The following is a description of a gene set: studied in species Homo sapiens Human Gene Set: VDR_Q6 Genes having at least one occurrence of the motif CNSNNTGAACCN in the regions spanning 4 kb centered on their transcription starting sites. This matches the VDR transcription factor binding site V$VDR_Q6 (v7.4 TRANSFAC)., and this is the list of marker genes: CFAP100, NDUFS2, SEMA4A, TMPO (thymopoietin), CDKN2B, WFIKKN1, FKBP14, FGF10, ZNF593, DNMT3A, RNF11, ASS1, VAX1, DNAJC11, CDK18, TMIGD1, TSSK3, SCML1, PPP2R2B, PDRG1, KIF1C, SPACA6, MTF2, MAPK6, ASXL1, PITPNM2, ZFHX3, NEO1, CCDC120, TMEM132E-DT, NGF, PIF1, C10orf71, LRRFIP1, NIPBL, CEBPB, VEZF1, KAT5, SOX5, GRK1, NTNG2, NECTIN1, DQX1, ZNF205 (NCBI Gene Id 7759), OTUD7B, TRIT1, TNR, BFSP2, SLC36A2, MAP4K2, CLOCK, ADCY2, PGGHG, LPCAT3 (NCBI Gene Id 10162), FOSL1, CYP26A1, PABIR3, KDM3A, CA11 (carbonic anhydrase 11, NCBI Gene Id 770), AGPAT3, OLFML2A, FBXO36, STRA6, ZNRF1, FBXL19, CDK15, ZC3H11A, TSSK4, RBPJ, RND3, ROCK1, ZNF710, FAM170A, LINC00314, IKZF2, GRIN2A, EBF2, CLTA, SLC7A7, CALCR (NCBI Gene Id 799), APOO, ARHGAP22, CCNL1, ROCK2, FOXA1, DMRT2, TUSC3, SSH2, EIF4E, SLC25A10, ZNF133, EFNA4, KLK8, KIF13A, HOXB6, TMEM150A, HOXA5, POLR3D, COX4I2, GPR158, PPP4R1, SRSF6, ADGRB1, PABPC1, ZNF688, BCAM, EMID1, LHX2, CHMP4B, PLEKHA8, CD3E, ATP2B3, HOXD3, ASB7, SNCB, ELF4, C6, VCAN, ABCD2, RPL3, FLYWCH2, GREM1, NR1D1, PYY, HNRNPR, ZSCAN20, MST1, HOXC4, PABPC3, NTRK2, ZNF532, TRIM29, MYT1, RABL6, SIPA1, CLUH, KLF15, ENPP7, SP7, HPCA, HHEX, FBXL20, HAUS3, MRTFA, PCF11, ID4, FBXL19-AS1, XPO1, LINS1, RARB, SLC39A11, FGF9, ARHGEF15, SPATA20, NRDC, ASAP1, KIF1B, GNB2, KLF4, ACO2, PIK3R1, S100G, ITM2B, ZNF800, MNT, GRIA3, PMP22, COL11A2, SAT1, MSI1, RNF123, RASIP1, DNAJC14, CD2BP2, CHMP2B, TRIM33, DMAC2, HOXB2, GRM3, BEX3, SIX4, GLI1, IRX4, KPNB1, CCNI, TSC22D3, ZC3H14, PKN1, PKP3, SEMA3B, ARL6IP1, ZPLD1, LAMP2, KCNJ13, STX6, RCOR2, GPBP1, AGO1, DDX17, ADGRL1, NCDN, TMEM185A, CD40LG, BARHL2, INCA1, SYNCRIP, ATP1B4, TMEM39A, BOC, CTLA4, ACOT8, TENM3-AS1, RAPGEF4, DLG2, GNL3LP1, PITX2, TMEM132E, CRHR1, ZNF503, RUNX1T1, TCF12, GSC, COL19A1, PHF21A, TFAP2C, EDN3, MACO1, TTBK2, SYT9, USF1, GBA2, OVOL1, ZSWIM3, KDM2A, SSBP3, TLNRD1, PAX6, CDX1, TSPAN13, SLC25A5, USP49, A1CF, ESRRG, PDGFC, RND2, CELF1, POLD1, RBBP6, SLC4A4, FAAP100, CD248, POU4F3, PODNL1, FXYD3, CLIC5, NLGN2, ARHGEF7, FOXD3, CXorf58, SYT14, SLC43A2, PCGF2, FGF14, GREB1, DDIT3, ADAMTS4, PCSK1N, CDK16 (cyclin dependent kinase 16), WNT5A (Wnt family member 5A), FGF17, CYP24A1, AZI2, PTCH1, ZNF219, PDHB, TBX2